The following is a description of a gene set: Human Gene Set: LHX9_TARGET_GENES Genes containing one or more binding sites for (LHX9) in their promoter regions (TSS -1000,+100 bp) as identified by GTRD version 20.06 ChIP-seq harmonization. species: Homo sapiens from publication Yevshin I, Sharipov R, Kolmykov S, Kondrakhin Y, Kolpakov F (PMID 30445619), and this is the list of marker genes: ADNP, NOL6, SYTL2, RN7SKP241, WBP2, CALM2, ETV5, MYL11, ENSG00000271860, ATP5MC1, GLRX5, LINC02923, NOP10, LINC02343, KHSRP, MIGA2, KLF14, ITGA2 (integrin subunit alpha 2), ZCCHC7, IGF2BP3, EIF4A3, LINC02547, USP1, LINC02551, BAALC, LINC02832, MASP1, LINC02288, EVA1C, SFPQ, SMAD1 (SMAD family member 1), SBF2, CCDC174, PAXIP1-AS2, CAPS2, ACP3, FRG1-DT (FRG1 divergent transcript), EIF3F, MIR4477A (NCBI Gene Id 100616184), PLEKHM1, PRCP, STAT2, H2BC13, DHX38, TK1, FRG1, LINC01344 (NCBI Gene Id 400799), EMC4, ACYP2, TMT1AP1, OPA1, SMTN, LINC02458, OPA3, MGC32805, ERAP1, RPL36AP19, RAB11B, TNK2, RPL15P12, NLN, CLEC16A, YJU2, ACOT8, DDX60L, SPATS2, LINC03033, RELCH, SLC25A28, METTL13, PBX1, ZNF286A-TBC1D26, SP2, IMMT, SNORD42B, MIR4676, INTU, TLR6 (toll like receptor 6), SP2-AS1, PECR, ARHGAP32, SMPD4BP, TPRG1-AS1, BST2, FCF1P7, COTL1, PCNX4, RTTN, PRKCE-AS1, INPP5B, ARHGEF37, ASNS, LYPD1, KCNK1, VEZF1, DDX12P (DEAD/H-box helicase 12, pseudogene), KIF14, LINC02261, FAM47E, ELF3-AS1, SERBP1, EEF1A1, MVB12A, PFKFB2, ATP5F1B, UFD1-AS1, GPATCH2, CXADR, PLPP5, EDRF1-DT, LINC03040, TRIB3, TMED10, PNP, ZFPM2-AS1, STK3, GRK6 (NCBI Gene Id 2870), SYMPK, TMEM41B, CRTC2, MRTFA, TNRC18, CAB39L, ANXA2, FBXO15, MFSD11, HDAC4-AS1, SNORD104, TMEM67, PATJ, SPATS2L, SNHG32, CRTAP, SPRED1, BAX, LIMA1 (NCBI Gene Id 51474), RFX1 (NCBI Gene Id 5989), ZNF235, HSPA1B (heat shock protein family A (Hsp70) member 1B), MED29, ZNF175, DEFB104A, TNKS2-DT, GEMIN8, PTBP1, TLR1, CFI, DCAF13 (DDB1 and CUL4 associated factor 13), DDX39B, RASL11A, DERA, CNOT3, RN7SL208P, DHX8, XPO6, PCGF6, LINC01303, PCNX4-DT, ARHGEF28, RNU7-29P, TUBA1C, ARL8B, FADS2, HARS2, CFAP69, LINC00910, ZSCAN31, TFDP2, RBM39, ADM, LYSMD3 (NCBI Gene Id 116068), KAT6B, ZFHX4, LEMD2, ABCC3, RHOF, DEAF1 (NCBI Gene Id 105376508), IL1RAP, CLK3, ABCA4, NDUFAF8, RNU4-1, PLPP3, MAT2B, SSR1, PAF1, GOLPH3L, MAN1C1, CNPY2, GPR108 (G protein-coupled receptor 108), RPL21P122, CEP78, MACC1, MRPL24, AKAP13, ZNF286A, MFSD6, AHSA1, DTX4 (NCBI Gene Id 23220), SNRPA1-DT, PHACTR4, ACTG1P17, CCNT1, DERL1, SHB, SELENOK, CNTN2 (contactin 2), MYPN, KLHL41, WDR62, SLC18B1, MBD1, FZD6, ZC3H6, FBXO16, RPL23A, LURAP1L-AS1, ARHGAP18, MCPH1-AS1, CDC23, DHX33, DNAJB5-DT, TTC31, TPM4, TTLL6, KCNAB1, UBE2D3, LRBA, EVI5L, RNU6-72P, FDPS, METTL17, PSMD10P2, POLR1HASP, UBTF, PLOD3, SPTY2D1, EIF2B5-DT, RPS14, CCDST, ZMIZ1, GOSR2, TEPSIN, PCLO, ZDHHC1, CREB5, SATB2-AS1, LINC02882, LNMICC, PREB, TPD52L1, BNIP2, EBP, ASPSCR1, DCT, PSMD8, CXCL8, DEGS1, SESN2, POLG, SLC25A44, ZNF225, FOXL1, SF1-DT, DCK, IMP4, CHP1, BDH1, MAU2, KLHL25P1, SLU7, SNORD13, DRAM2, FRRS1, DUSP7 (NCBI Gene Id 1849), SMC4, NT5DC3, RNU6-266P (RNA, U6 small nuclear 266, pseudogene), PRRG2, CYP1B1-AS1, WWOX, RBM14-RBM4, SIN3B, CDK19, SULT6B1, PNPO, AKAP1, UBE2HP1, FEZ2, H3C12, LINC01132, ADAR, AZI2, RAB2B, RTKN, ARL17A, MIR3165, CUX1, NUP35, IWS1, SMAGP, DSC2, MAP1S, TMCC1, LARS1, KRT23, DENR, EIF3D, ZNF251, TYW3, UNC13B, SAMD13, FNIP2, DLG5, ZNF304, MRPS33, EPB41L2, CCDC33-AS1, HSPB1, FANCM, MIOS-DT, IRX4, TDRKH, TMEM127, ZFX, PNPT1, NEK7, ENSG00000267174, EIF3E, RPS24P12, FKBP3, ANAPC15, NOSIP, ATF3, ADGRF4, CD83P1, SP1, JTBP1, C1QTNF6, LINC02292, IFRD1, CYBRD1, ZNF669, LINC02073, NEXN-AS1, RIOK2, TMC5, ADD3-AS1, AKAP9, KRTAP3-3, H2BC5, ELF1, LINC02541, NECTIN2P1, OR12D3, MST1P2, TMEM167A, IFT80, BTNL12P, CSNK1A1, GANAB, VPS50, ABR, DCTN4, URGCP, ANAPC13, TRIM24, ATP6V1D, MUC20-OT1, GRAMD2B, ACAA1, SH3GLB2, SF1, EAF1, FAM230G, IFT57P1, MAPK8, ALKBH7, MIR615, ZNF749, FSTL4, GSR, ADD1, ZSWIM3, STX18, TXNRD2, SLX4IP, THAP7, EIF2B4, NCOR2, NFYA, VDAC2 (NCBI Gene Id 7417), POT1-AS1, SMARCA4, RTN4, HOXA9, GOSR2-DT, CTDNEP1, MFSD14CP, RN7SL346P (NCBI Gene Id 106479350), CNTD1, ECE1, RAB33B, VPS33B-DT, GOLM1, STAT3, PCYOX1L, SLC25A28-DT, AMZ2P1, GRHL3 (grainyhead like transcription factor 3), SMG8, C1orf226, LYRM7, LINC02243, SLC9A4, YJU2B, NXN, CCDC115 (NCBI Gene Id 84317), DNAJB5, PMAIP1, CFL1, ZNF146, ZBTB11, LINC02331, KPNA1, RAB7A, CCT8, WDR1, GEM, PHB1, MSX2, CRYBG1, AHCYL2, WDR19, ALG10, H2AC11, NEBL, ATP5PF, POLR3A, TYW1B, SAMD4A, ADAMTSL5, H2AC4, RPS19, COPE, NRDC, TMEM70, NUSAP1, MNT, PBX2, LINC00511, LINC01182, REXO1, MCC, GPR107, IFNAR1, SUPT4H1, DENND2B-AS1, ETFBKMT, RAI14, RPL32P9, ZNF713, PPID, FGL1, ELMOD3 (NCBI Gene Id 84173), ADGRG6, PSMB1, C15orf61, HGSNAT, PLEKHH3, CASP6, VPS37C, ENTREP2, MGST1, ENSG00000239137, NPIPB8, KATNB1, ZNF263, RPL22L1, CCDC59, DNER, TEDC1, MTAP, JMJD1C, TRMT1, CRYGC, RAB3D, ACVR1, TBP, RBM48, NCOA2, ING1, SFN, MZT2A, RPS6KA1, SYNE2, CD274, MTA3, TMC1, YARS2, ARHGAP10 (Rho GTPase activating protein 10), ANKRD44, HCG25, TBC1D9, MIR1289-1, SLC16A1, MTHFD1L, ARMH1, H3C10, GATA2, ARL14EPL, PPP1R37 (protein phosphatase 1 regulatory subunit 37), KDSR (3-ketodihydrosphingosine reductase), RSPO2, RMC1, RNF10, TMEM243, CCN2, CACYBP, TDRKH-AS1, PIERCE2, ANAPC11, SNORA50C, MYO10, YPEL5, PPIL3 (NCBI Gene Id 53938, peptidylprolyl isomerase like 3), GPR156, GTF3C2-AS2, BTRC (NCBI Gene Id 8945), EHD1, MUCL1, MIR22HG, TTF2, ELP5, LINC02901, ENSG00000272217, H2BC26, GTF3C5, SLC4A7, C2CD2L, PRPF19-DT, BNIP1, RHOBTB3, USP44, AFMID, LY6K, HOXA7, UBB, SNX17, LINC02577, UPP2, OTUD4, DNAJB6, GIRGL, MAGIX, CENPF, OIP5-AS1, UBP1, UBALD2, NSUN4, HABP2, FOXO4 (forkhead box O4), MAP3K9, IGF2BP2, INO80C, APOO, DHX30, RN7SL606P, AP1AR (adaptor related protein complex 1 associated regulatory protein), CD68, CENATAC, BRD2, ZMAT2, AIRIM, PIH1D1, CEPT1, C22orf39, MSTO1, RPS20P4, SLC35F2, MIR3617, NFIB-AS1, RUFY3, CLCN3, GBA1, ABHD12, TUBGCP3, VCP, MTCO3P12, OXR1, LINC02944, SEMA3B, LINC00460, HEXIM2-AS1, INTS10, BAZ2B, PNN, WASHC3, TBC1D30, ENSG00000234859, LY6G5C (NCBI Gene Id 80741), RAB5B, CYP20A1, FNIP1, SMUG1, CCDC192, ASPH, CLIP4, MIR100HG, TDRD3, LARP4, PCLAF, TXNL4B, YIPF4, CEP76, SPOP, SCAF1, TXNRD1, SHROOM2, RPL17, AOPEP, DCBLD2, CENPT, DHX16, USP2, PCAT19, RPSAP52, NUDCD1, FBXO34, CLEC4OP, EIF2AK3, CDK12, CIDECP1, EML2, SNRPB, KIAA0513, SMIM12, HIBADH, LTBP1, NEK10 (NIMA related kinase 10), RBM20, NBR2, SLC41A2, SPG11, DARS1-AS1, ZFP62, COMMD4, TPM1, RPS26P29, PPP1R42, GPRC5B, LIVAR, ZNF558, RALGPS2-AS1, SCTR-AS1 (SCTR antisense RNA 1), CDK5RAP2, FBXL2, RBBP5, GLO1, PHLDB1, EMC7, DST, ID2, EIF2AK3-DT, CCNG2, SHROOM3, ENSG00000253270, ELP2, TANK, DBF4B, COX7B, SNORA73B, SPOCD1, H2BC20P, RGS20, ENSG00000249236, TBCD, ZNHIT1, LINC02739, HPGD, PRKCH, LRRC23, MLEC, CCND1, TUT1, EXPH5, MIR9-2HG, ATP2C1, OSBP, SCOC, TLX3, UTS2B, SNRPA1, SNRPG, VPS39, GAR1-DT, PPP2R5B, ABT1, IGLV3-19, NF2, SCO1, ABI2, GTF2H4, RNU4-18P, ZNF565, EHD4, DLGAP1-AS2, PRKCE, RBIS, ABLIM1, ARL16, OARD1, PCM1, PLEKHA6, PLA2G4E-AS1 (PLA2G4E antisense RNA 1), RNY3, EML1, PFDN5, ADAMTS17, MTFR2, ZNF688, KRTAP1-3, SLC4A3, LINC01392, KDM1A, DUSP23, SUGP1 (SURP and G-patch domain containing 1), DNAH11, SLC4A1AP, LAPTM4A, TIMM21 (translocase of inner mitochondrial membrane 21), KTN1, IGLV3-24, KRTAP2-4, MCRS1, ENSG00000247193, TLK2, MATR3, SKIDA1, GBA1LP, TMEM60, CCDC18-AS1, EIF4E, MIR4682, ZNF451-AS1, SHF, MPND, YAP1, HDGFL2, WARS1, PGBD4, SPPL2B, H3C4, SCUBE1-AS1, RNU6-784P, ATG2A, TRIP10, CORO2A, IRAK4, POLR1D, HOXC-AS1, PRNP, LINC00111, ATP6V1FP2, PAFAH2, TBC1D10B (TBC1 domain family member 10B), KRTAP4-9, LYPLAL1, RAB11B-AS1, TPM3, ACOX3, HMGA2, GSN, PSMB7, CENPL, SAMD11, MGP, MT-TT, SEMA3A, TRAF3IP2, CLASP1, LINC01997, PORCN, FBXO5, OIP5, S100A11, GDF5, GAR1, DDX47, MYCBP, GOT1-DT, SUPT7L, DYRK4, LLGL2, SRD5A3, GRHL3-AS1, MPDU1-AS1, JUP (junction plakoglobin), KIAA0319, ABCA6, ARMH4, PLXNA4, ZW10, HMGA1 (high mobility group AT-hook 1), TMX2, SBDSP1, RPS29P16, RGS17P1, UBAP1, ZBTB20, RGS9, APH1A, PYM1, CCDC159, STPG4, MDC1, HAPSTR1, MAP9-AS1, BBS9, CEBPZOS, LINC01515, CCT6B, GNAI2, KRTAP2-3, CUEDC1, RNF181, MMP1, MT-TE, HMGN1P33, HELZ, TATDN1, IL1R1, CRYZ, TMEM205, MDGA1, MIR7-2, HOXC9, LYPLAL1-DT, ANKRD17, PDGFC, SNORD118, CCDC142, SLC25A37, SLC39A6, MAP2K5, DPCD, GATA2-AS1, LINC01426, CD70, STXBP5-AS1, CARNMT1-AS1, ENKUR, TIPARP, RABEPK, GIN1, CPVL, DHX33-DT (DHX33 divergent transcript), ID2-AS1, MIR4755, PTPRH, DAD1, ALKBH5, N4BP2L2, MRPL51, RHOBTB2, RNF125, PSMC1, SRSF2, CCDC149, COQ5, ZNF608, RPL3, PRKAR1A, LRRK1, GUCY2GP, COPS4, MT-RNR2, CDC42EP3, HNRNPU, LINS1, DRD2, NIP7, POLR1H, SND1, VPS36, PDIA3, MIR4999, HLA-DRA, TNKS1BP1, RN7SL329P, PEBP1P1, INPP4B, LINC02890, PSEN1, RNF43 (ring finger protein 43), PFN2, COL4A6, KIF1B, PHB2, MMS22L, TIMM44, NDUFB3, ACACA, RRAS, LINC02098, COPZ1, ITGB5, DENND4A, RBBP8, FCSK, SCNN1A (sodium channel epithelial 1 subunit alpha), COG8, C2CD3, PCDH7, MT-TP, ANKH, VARS2, GTF3C2, ARB2A, RPN2, MIR4466, SDCCAG8, PA2G4P4, PALB2, AADAT, FRYL, GAS7, RNF44, ELOC, LINC01350, SRSF8, ENSG00000267882, CTH, MCU, IFI6, RBM4, RN7SL635P, PLAAT3, KLHDC8B (kelch domain containing 8B), MT-ND6, RAD1P1, GNPNAT1, TMEM126A, PHLDA1, CPLX2, STAP2, RLBP1, CSTF2T, ERP27, TMEM106A, CISD1, PSMA3-AS1, WDR25, SCD, ALDH18A1 (aldehyde dehydrogenase 18 family member A1), CFLAR-AS1, KPNA2, ZNRF1, CTNNBIP1, CASP4, SEL1L, LINC01411, BISPR, MT-TL1, CDH26 (NCBI Gene Id 60437), IL1F10, RNA5SP429 (NCBI Gene Id 106480767), RHEB, NIFK-AS1, RNU6ATAC10P, PPFIBP1, ENAH, FRMD6, POLG-DT, A1CF, PDP1, ENSG00000238185, GIGYF2, BCL6, ING4, GALNS, MFSD12, VN1R7P, MALSU1, SAP30BP, DGUOK-AS1, KRTAP3-1, IPMK (inositol polyphosphate multikinase), B3GNT5, PAM, KRT80, LINC00518, TACO1, DPF3, MIR6797, ZNF555, FRMD4A, KBTBD11, SZRD1, NET1, LINC00358, ALDH3A2, PHTF2, GALM, VPS41 (VPS41 subunit of HOPS complex), GOLGB1, IRS2, CEP97, MIR4645, TMEM126B, DDX49, RPL5P11, COPS3, PCBP1-AS1, SORBS1, EIPR1, COX6C, CHN2, CUEDC2, CA13, LINC02136, FANCD2, PFKM, CHD2, VWA7, FGD5-AS1, LINC01675, COQ10B, TOMM40L, GLI2, FZD2, SNORD1C, ZMYND8, PPP4R3B, SNORD84, KMO, MITD1, P4HB, PARS2, TLE3 (NCBI Gene Id 7090), GRWD1, VPS33B, ARL14, GNA12, GEMIN2, DMKN, FAP, PRPSAP1, CXXC1, TTC39C, ARAP2 (NCBI Gene Id 23278), PARN, RERE, PXN, TMED7, RAB11A, BMP4, SLC20A2, RPL39P40, WDPCP, MT-ND1 (mitochondrially encoded NADH:ubiquinone oxidoreductase core subunit 1), CFDP1, CRYGS, COX7A2, SKA2, ECSIT, ALOX12P2, NIF3L1, SPRED2, THBS4, FAM111B, GBF1, CNOT1, SNORD43, LIN37, TEX15, COL4A5, NDEL1, SNHG22, PHLDA1-DT, GRHL2 (grainyhead like transcription factor 2), FBXO34-AS1, LUCAT1, DGKA, VMP1, PPP3CA, GABPA, CALCRL-AS1, STK10, USP54 (NCBI Gene Id 159195), CEP112, NUTM1, EIF3H, SEC24A, PRR13, CSNK1G1, CROCCP2 (CROCC pseudogene 2), TMEM53, OVOL1-AS1, STPG1, PALLD, FAF1, SSR3, TGFBR2, SNHG10, HPF1, ELL2, NGEF, ATF6, CECR3, H2BC4, KCNIP2-AS1, LGALSL, RNF214, DEXI, CAP1, GINM1, DNAJB12, CEP250, ENSG00000272195, MDH1, TMED7-TICAM2, VPS45, BRCA1, STOX2, RNU5E-1, C9orf40, TOMM40, ATP5IF1, VOPP1, HRG-AS1, NDUFB9, HDAC4, TDP1, SNORD114-28, XPC-AS1, RETSAT, MPRIP, NFATC2IP, ECHDC1 (ethylmalonyl-CoA decarboxylase 1), SGMS2, RPL17-C18orf32, CEP63, LINC00682, PTPN6, ALDH1A3-AS1, PALMD, ASCC1, ITSN1, H2AC6, CACFD1, ABCA15P, MTMR4, SLC22A5, YOD1, ITGA1, TRAPPC2L, PDCL, VPS35L, SNRPC, NCAPD2, H2AC25, LINC01275, PPP6R3, TCERG1, CSNK1E, RCAN1, PSMC2, CYTH1, MYH9-DT, ENSG00000200999, GCNT2P1, PANK2, FRMD3, S100A2, CDIN1, GBP5, DSCAML1, MIR1206, EXTL2, SMAD7, EIF1, MKLN1-AS, SEPTIN7P1, BAHCC1, BZW2, XKR9, TBC1D22A, UBE2R2-AS1, MT-TV, PIK3C2A, LINC00484, ANKRD40, NDUFAF1, ZC2HC1C (NCBI Gene Id 79696), P2RX6, RTN4IP1, PGLYRP2, MIATNB, GLIPR1-AS1, ZFHX3, ANKRD28, TCF7L2, MED19, BCL2L2, DEPTOR-AS1, CD6, FLAD1, BACH1, PEAK1, MYH9, TADA2A, LINC01089, LDHA, AGR2, BCL2L15, NGDN, VIPAS39, TMT1A, HYCC2, SAP30BP-AS1, OGA, DLG1, HAT1, DARS2, ADM-DT, KIAA1217, GPR3, HIVEP3, LRRC51, MPP4, FIZ1, GLIPR1L2, NR2E3, APBA1, CTHRC1, LINC02985, BCAS2, CREBL2, TMEM123, COPS7A, TNRC6B, FHL1, BIRC3, DCTN5, PNRC2, RALGAPB, SH3PXD2A-AS1, PUM1, HMGA2-AS1, ALDOA, FADS1, MKRN2OS, CPOX, ARID4A, ODAD2, DLGAP1-AS1, SLC26A7, RBM14, GLIDR, GSAP, USE1, PCGF1, LINC00513, PEX1, RNU7-59P, TOX4, TRAV8-3 (NCBI Gene Id 28683), RMND5A, WEE2P1, ARNT, NCF4-AS1, CDCA2, FUZ, NR0B2, ADGRF1, TARS1, NKX3-2, HEXIM2, GTPBP1, MTX3, LRRC58, TTC23, ANK1, MEF2C, TESK2 (testis associated actin remodelling kinase 2), GUCY1B2, WIPF2, LINC00398, MACF1, RNU6-969P, DPAGT1, MSANTD2, VPS25, NEDD4L (NCBI Gene Id 93998), TK2, CDKAL1, SLC35B1, EMC9, FOXA3, NAMPT, COX6A1, SNORD114-22, TARS1-DT, HARS1, AGPAT4, WWTR1, TASP1, SLC9A1, LDAH, SMARCD3, ATG10, GATAD2B, CNPY2-AS1, FNDC3A, KPNA4, LSM5, SAPCD2, DLG2, NCEH1, LIM2-AS1, RFFL, HBP1, MIR4799, TBC1D10A, PIM1, ADIPOR1, ZSCAN9, ZFYVE26, GRPEL2-AS1, FRMPD2, HOXB8, ENSG00000263280, ZNF281, TRAPPC9, MIR320C1, ADAMTS7P4, CYREN, SERAC1, PHLPP1, PSMB5, MCCC2, TIAM1, ID3, RPL6, CLPP, SND1-DT, CDKN2C, FABP5 (NCBI Gene Id 92424), RBM25, KDM5A, U2SURP, ENSG00000221345, USF1, KIFC3, GULP1, GOT1, WSB2, MDM1, CBX5, PIK3R1, SNHG25, HEATR1, HRH1, USP38, METTL25, DENND2B, KBTBD2, HLCS, PUM3, C1RL, ENC1, ADCY7, FBXW7, SULT2B1, CD44-AS1, UTP3, PRPF40B, SLC25A32, LINC00323, ENSG00000276527, BAZ1A (bromodomain adjacent to zinc finger domain 1A), CPEB2, DNAJC1 (DnaJ heat shock protein family (Hsp40) member C1), RIC8B, GBP3, TFB1M, EMG1, BPIFC, STAMBP, MICU2, PSCA, FBXO46, ARID1B, C4orf36, IRX4-AS1, TRBV14, MLIP, TRIP4, NAIF1, SLC38A10, LINC01895, SCP2, ZNF770, NME1-NME2, KRT15, NDST3, CREM, TTI2, DKK4, BLID, RPL7AP82, SNAI3, EIF2B5, QRSL1, DUSP6, MSI2, PMEL, CLCC1, COX6CP7, POLL, RNU6-433P, RNF169, LHB, HOXA-AS2, SNORD48, SRI, LIMCH1, MKKS, CS, ENY2, RPUSD2, DBR1, AFF1, B4GALT4, NR2F2, EFCAB5, TXK, COA3, UCA1, CHCHD5, GORAB-AS1, CDCA7L, ACTR1A, PPIP5K2 (NCBI Gene Id 23262), PGK1 (phosphoglycerate kinase 1), HMG20A, ACOX2, HGS, KRTAP9-12P, SLC25A25, ITGAV, CD44, AP1AR-DT, RECQL5, UCA1-AS1, TCF12, GBE1, STRA6, HMGB2, TNRC6B-DT, FGD6, HCG14, OTUB2, WFDC10B, GSN-AS1, THAP1, POU2F1, PRR11, TEX12 (testis expressed 12), WWP1, ELP3 (elongator acetyltransferase complex subunit 3), GALNT5, CLNK, TMEM245 (transmembrane protein 245), CCT6A, ARID1A, LINC00609, SATB2, EFCAB11 (NCBI Gene Id 90141), ISOC2, LAPTM4A-DT, DKK1, LINC01111, DENND3, RPS24, SGPP1, PFDN4, SLC7A8, TRMT44, MSANTD4, XPNPEP1, DNAAF3, PRR14, ZNF524, CTSB, EGFR, ABCA7, LINC01589, NME1, PCID2, SEMA6A, RBM47, PRECSIT, RRAGC-DT, RNF220, ST8SIA6, MIR4650-2, MYC, AIG1, KRT8, CRPPA, ENSG00000187185, RNU6-97P, DNMBP, ZNG1E, LEKR1, COX16, ANKRD54, UTRN, COIL, IQCH-AS1, EHBP1, ATF6-DT, CYP2R1, ELOBP4, LINC00963, LINC01094, GPR180, S100A10, CEP120, ATOSA, CAPNS1, ZFAND6, FOXN3, C10orf55, TMEM222, EHMT2, LINC01234, CYB5B, METTL6, CWC22, DCTN1, SAE1, ZNF738 (NCBI Gene Id 148203), ALDH1A2, FZR1, RUVBL1, ABL2, PUS7L, ZNF267, SETD5, SLC11A2, FBXL19, LINC01363, ZNHIT3, CYLD-AS1, PAPLN, LIX1, NUMA1, LATS1, CSDE1 (cold shock domain containing E1), GJC1, POU2F3, VPS39-DT, CREBRF (CREB3 regulatory factor), RNU6-107P, ELF3, ACSS2, PRPF19, LHFPL5, ZNF227, ZNF195, MGAT5B, LINC01970, C5orf46, TPGS1, ZNF225-AS1, TM9SF4, ENSG00000235480, TMPRSS11F, DRAIC, GASAL1, TPRG1, PACS1, DDX10, KCNJ13, FDXR, FBF1, LINC02068, CARD10, NFATC4, PAFAH1B2P1, ALG9, RN7SL674P, PARD3, POLR3B (NCBI Gene Id 55703), MIOS, CAPN3, CASC11, NFYC (nuclear transcription factor Y subunit gamma), LINC02205, HIRA, H2AC13